The following is a description of a gene set: The gene expression program underlying the specification of human cell types is of fundamental interest. The study authors generated human cell atlases of gene expression and chromatin accessibility in fetal tissues. For gene expression, the study authors applied three-level combinatorial indexing to >110 samples representing 15 organs, ultimately profiling ~4 million single cells. The study authors leveraged the literature and other atlases to identify and annotate hundreds of cell types and subtypes, both within and across tissues. Our analyses focused on organ-specific specializations of broadly distributed cell types (such as blood, endothelial, and epithelial), sites of fetal erythropoiesis (which notably included the adrenal gland), and integration with mouse developmental atlases (such as conserved specification of blood cells). These data represent a rich resource for the exploration of in vivo human gene expression in diverse tissues and cell types. Marker genes curated from the annotated cluster as represented in the Descartes Human Gene Expression During Development database. Human Gene Set: DESCARTES_FETAL_STOMACH_PDE1C_ACSM3_POSITIVE_CELLS from publication Cao J, O'Day DR, Pliner HA, Kingsley PD, Deng M, Daza RM, Zager MA, Aldinger KA, Blecher-Gonen R, Zhang F, Spielmann M, Palis J, Doherty D, Steemers FJ, Glass IA, Trapnell C, Shendure J (PMID 33184181) species: Homo sapiens, and this is the list of marker genes: ADARB2, SHISA2, STAC2, RHOBTB1, ACSM3, PDE1C, NOX4, PSEN2, ATP6V0D2, CNBD1, ATP6V1A, CPSF7 (cleavage and polyadenylation specific factor 7), MFSD6L, TFCP2L1 (transcription factor CP2 like 1), FOXI1, WNK3, GABRB2, STUM, AMACR, ATP6V0A4 (ATPase H+ transporting V0 subunit a4), KCNE4, ERBB4